The following is a description of a gene set: Spastic diplegia Human Gene Set: HP_SPASTIC_DIPLEGIA Spasticity (neuromuscular hypertonia) primarily in the muscles of the legs, hips, and pelvis. studied in species Homo sapiens, and this is the list of marker genes: TAF1, PDHX (pyruvate dehydrogenase complex component X), RNU7-1, AP1S2, SIX6, SIGMAR1, SPTLC1, NDE1, RNU4-2, ALDH3A2, GALC, HSD17B10, FUS, ACP5, NAA10 (N-alpha-acetyltransferase 10, NatA catalytic subunit), HUWE1, SOX2, SLC25A15, TUBB3, DARS1, RAB3GAP1, AARS1, ELP2, GCDH, PSAP, ADD3, GLRX5, TANGO2, AASS, PQBP1, PNP, SPTBN1 (NCBI Gene Id 91654), RAB3GAP2, FLNA, HSD17B4, ALS2, BCOR, SPG11, CTNNB1, NTRK2, NDUFA4, H4C5